Given this list of marker genes Prkacb, Raf1, Rasgrp1, Rasgrp2, Rap1gap, Ywhaz, Rap1gap2, Ywhab, Rap1b, Rapgef4, Rap1a, Sipa1, Prkaca (NCBI Gene Id 18747), Rapgef3, Prkg1, here is a description of the gene set: Mouse Gene Set: REACTOME_RAP1_SIGNALLING studied in species Mus musculus Rap1 signalling